The following is a description of a gene set: Cellular response to starvation species: Homo sapiens Human Gene Set: REACTOME_CELLULAR_RESPONSE_TO_STARVATION, and this is the list of marker genes: CASTOR2, RPS3, TRIB3, ATP6V0B, RPL36A, ATP6V1E2, RPS15A, ITFG2, RPL35A, SZT2 (SZT2 subunit of KICSTOR complex), DEPDC5, IMPACT, RPL4, LAMTOR5, EIF2S3, GCN1, ATP6V1C2, RPLP2, RPL23A (ribosomal protein L23a), RPS19 (ribosomal protein S19), RPL22L1, RPS7, RRAGC, RPS6, RPL28, ATP6V1A, RPL36, TCIRG1, SAMTOR, RPL39L, RPL29, RPL10, RPS2, RPSA, RPL26, UBA52, NPRL2, SH3BP4, RPLP0, RPS27L, LAMTOR3, MTOR, RPS4Y2, RPL41, ATP6V1H, RPTOR, SESN1, FNIP2, RPL17, RPL14, RPL31, RPL3L, RPS4Y1, KPTN, RPL13, RPS5, KICS2, RPL39, RPS25, RPL32, MLST8, RPS24 (NCBI Gene Id 6229), RPS9, RPS12, ATP6V1E1, ATP6V0D2, CEBPG, SLC38A9, RPL23, ATP6V0E1 (NCBI Gene Id 8992), ATP6V1G1, RPS15, CASTOR1, RPS29 (ribosomal protein S29), RPS26, RPS17, RPL37A, SEH1L, RPS21, RPL21, ATP6V1G3, RPS16, ATP6V0D1, RPS10, ATP6V1G2, RPL10L (ribosomal protein L10 like), RPL24, ASNS, RHEB, RPL35, RPLP1, DDIT3, RPL30, RPL38, RPL18A, RPS18, RPS27A, LAMTOR1, RPS14 (ribosomal protein S14), ATP6V1B2, SESN2, RPL22, ATF4, RPL3, RPS8, RPL12, RPS13, LAMTOR4 (late endosomal/lysosomal adaptor, MAPK and MTOR activator 4), RPL26L1, EIF2AK4, RPL9, RPS4X, RPL18, RPL7, RPS3A, NPRL3, EIF2S1, RPL8, ATP6V0C, RPL34, RPS28, MIOS, RRAGD, ATP6V1C1, WDR59, RPL27, RRAGB, EIF2S2, RPS23, RPL27A, ATP6V1B1, RPS20, FLCN, RPL10A, ATP6V1D (NCBI Gene Id 51382), RPL7A, RPS27, WDR24, RRAGA, ATF3, RPL6 (ribosomal protein L6, NCBI Gene Id 6128), RPL36AL, ATP6V0E2, FNIP1, LAMTOR2, RPS11, RPL19, SEC13, FAU (FAU ubiquitin like and ribosomal protein S30 fusion), CEBPB, RPL37, RPL13A, RPL11, RPL15, RPL5, ATF2, ATP6V1F